The following is a description of a gene set: This event has been computationally inferred from an event that has been demonstrated in another species.<p>The inference is based on the homology mapping from PANTHER. Briefly, reactions for which all involved PhysicalEntities (in input, output and catalyst) have a mapped orthologue/paralogue (for complexes at least 75% of components must have a mapping) are inferred to the other species. studied in species Mus musculus part of: Regulation of endogenous retroelements Reactome Pathway: Regulation of endogenous retroelements by KRAB-ZFP proteins electronically inferred by orthology from the curated human pathway, and this is the list of marker genes: H2ax (H2A.X variant histone), Gm5141, H2ac4, H3c7, Zfp990, Gm45871, Zfp994, H2ac23, H4c12, H2ac15, H2ac24, H4c14, Zfp141, H3c1 (H3 clustered histone 1), H3c8, H3c15, Zfp943, Zfp874b, H3c10, H4c3, Zfp946, H3c4, Zfp677, H2bc3, H4c11, H4c8, Gm10033, H4c1, H2ac19, Zfp987, Gm14325, H2bc15, Zfp324 (zinc finger protein 324), H2bc7, H2ac20, Zfp947, B020011L13Rik, H3c2, H2az2, Zfp119b, H2bc11, Gm7072, Zfp872, H2ac10, H2bc1, Gm14391, Zfp992, H4c17, Zfp454, H3c3, H2ac8, H4c6, H2bc9, H2ac1, H4c9, Zfp317 (NCBI Gene Id 244713), H2ac13, H4c18, H3f3a, H2ac7, H2ac22, H2bc22, Zfp971, H3c6 (NCBI Gene Id 319151), H2ac12, H3c13, H2bc12, Zfp989, H4c2, H2ac11, Zfp982, H4c4, Zfp991, Zfp758, H2bc8, AU041133, Gm4924, Zfp383, Zfp934, Zfp995, Zfp354a, Zfp942, AI987944, H3c11, H2bc13, H2bc27, H2ac6 (H2A clustered histone 6)